The following is a description of a gene set: Broad distal phalanx of the toes species: Homo sapiens Human Gene Set: HP_BROAD_DISTAL_PHALANX_OF_THE_TOES Increased width of the distal phalanx of toe of one or more toes., and this is the list of marker genes: HOXD13, FGFR1, MED25, HS2ST1, FGFR2